The following is a description of a gene set: Human Gene Set: HP_SINUS_TACHYCARDIA Heart rate of greater than 100 beats per minute. species: Homo sapiens Sinus tachycardia, and this is the list of marker genes: SDHD, NF1, MYH7, SDHB, SDHAF2, RET, ABCC6, EPAS1, SLC25A11, SDHA, DNMT3A, DEPDC5, ARSB, VHL, FH, MDH2, RYR1, MYPN, TPM3, BANF1, SDHC, TMEM127, MAX, PEX5, TPM2, DLST, GAA, KIF1B